Given this list of marker genes BMP5, BMP6, CLCN2, REST, WNT4, BMP2, DKK3, DAB2, here is a description of the gene set: studied in species Homo sapiens Any process that modulates the frequency, rate or extent of the chemical reactions and pathways involving aldosterone. Human Gene Set: GOBP_REGULATION_OF_ALDOSTERONE_METABOLIC_PROCESS